Given this list of marker genes Acsm2, Ugt1a1, Ugt1a6a, Glyatl3, Gstz1, Nat1, Podxl2, Slc35d1, Ugt1a9, Gstp1, Ggt5, Gstm1, Ugt2a3, Ggt1, Gsta3, Sult6b1, Ugt2b1, Ugt2b37, Gstm5, Tpmt, Ugt2b36, Ugt3a1, Ugt2b38, Gstt1, Hpgds, Ugt2b35, Chac2, Acsm4, Acsm5, Mat1a, Gsta1, Abhd10, N6amt1, Sult1b1, Ugt2a1, Acsm1 (NCBI Gene Id 117147), Ggt6, Ugt1a5, Ugp2, Trmt112, Gsta13 (NCBI Gene Id 100042295), Gstm2, Nat2, Ugdh, Ugt1a8 (NCBI Gene Id 613123), Gsta2, Chac1, Nat3, Mat2a, Ugt2a2, Nnmt, Gstt2, Ggt7, Ugt1a7c, Cyp1a2, Bpnt1, Sult1c2, Gstm6, Mgst2, Mtrr, Oplah, here is a description of the gene set: part of: Biological oxidations Reactome Pathway: Phase II - Conjugation of compounds This event has been computationally inferred from an event that has been demonstrated in another species.<p>The inference is based on the homology mapping from PANTHER. Briefly, reactions for which all involved PhysicalEntities (in input, output and catalyst) have a mapped orthologue/paralogue (for complexes at least 75% of components must have a mapping) are inferred to the other species. studied in species Mus musculus electronically inferred by orthology from the curated human pathway